The following is a description of a gene set: Mouse Gene Set: GOBP_ORGANIC_HYDROXY_COMPOUND_TRANSPORT studied in species Mus musculus The directed movement of an organic hydroxy compound (organic alcohol) into, out of or within a cell, or between cells, by means of some agent such as a transporter or pore. An organic hydroxy compound is an organic compound having at least one hydroxy group attached to a carbon atom., and this is the list of marker genes: Slco1c1, Gnat1, Gramd1c, Asic3, Kcne2, Apoa5, Slc2a13, Star, Ces1f, Xlr4a, Slc51b, Slc10a6, Slc5a11, Htr6, Nfkbia, Abcd3, Sec24a (NCBI Gene Id 77371), Kcnk9, Spp1, Cyp7a1, Syk, Prkn, Shh, Trem2, Stard3nl, Tor1a, Abca8a, Dtnbp1, Nfkb1, Abca5, Slc22a3, Fev, Htr7, Relch, Abca2, Slc18a3, Aqp9, Grm2, Kcnq1, Gpihbp1, Gpm6b, Hrh3, Vps4b, Agtr2, Abca12, Zdhhc8, Fcer1g, Apof, Itgb3, Nos1, Park7, Tspo, Emb, Nisch, Vapa, Drd3, Slc22a1, Lrp1, Bmp6, Ralbp1, Htr1b, Ldlrap1, Tmem97, Nr1h4, Abca7, Nr1h2, Mexis, Abca13, Abca1, Vip, Slc29a3, Aqp8, Slc18b1, Chrna4, Cd300a, Ces1d, Apoa4, Sncg, Atp8b1, Kdm5b, Rab3a, Agt, Oxt, Cav1, Ttc39d, Slc22a2, Ces1a, Slc6a4, Adipoq, Mip, Gdnf, Tgm2, Grk2, Slc16a1, Vps53 (VPS53 GARP complex subunit), Ghrl, Scp2, Abcb4, Rtn4, Tspo2, Nucb2, Actb, Drd2, Maob, Drd1, Flvcr1, Apoc2l, Npc1, Abcg1, Pltp, Arl8b, Pink1, P2ry12, Slco1a1, Gramd1b, Kpna4, Cftr, Ecrg4, Fcer1a, Mfn2, Nmb, Comt, Myo5a, Osbp, Pcp4, Furin, Adora3, Adora2a, Aqp7, Lamtor1, Xlr4b, Sirt1, Hnf1a, Tpcn2 (NCBI Gene Id 233979), Abcc2, Npc1l1, Smpd3, Slc5a12, Abcb11, Slc10a4-ps, Abca3, Rab3b, Nat8l, Oxtr, Snca, Stx12, Slc10a5, Ptch1, Flvcr2, Apoa1, Pip4k2a, Nus1, Myb, Slc10a4, Aqp2, Lipg, Slc16a8, Abcg8, Lipc, Ces1h, Vps52, Apoc2, Ces1c, Slc18a2, Abcc3, Prkcb, Slc44a1, Entpd1, Gps2, Lrp6, Slc10a3, Crhr2, Rbp4, Chga, Crhr1, Vps51, Slco1a6, Soat2, Oprk1 (opioid receptor, kappa 1), C1qtnf1, Cadps, Vapb, Stard5, Ptgs1, Ffar3, Abcg5, Apom, Slc5a8, Abat, Slc10a7, Plcd1, Slc6a2, Ceacam1, Adora2b (NCBI Gene Id 632506), Xbp1, Stra6l, Cartpt, Vps54, Npc2, Egf, Pla2g10, Apoc3, Nrg1 (NCBI Gene Id 320603), Ptpn11, Naxe, Tsku, Slc6a3, Chrnb2, Slc10a1, Slc26a6, Lcat, Myc (myelocytomatosis oncogene), Apob, Agtr1a, Crh, Slco1a4, Ptger3, Cnr1, Washc1, Slc16a3, Ceacam2, Snord60 (small nucleolar RNA, C/D box 60), Slc51a, Fgf15, Osbpl2, Soat1 (sterol O-acyltransferase 1), Stra6, Chrna6 (NCBI Gene Id 58169), Aqp11, Chrna7, Acacb, Slco1a5, Slc16a7 (NCBI Gene Id 71535), Syt11, Htr2a, Nr0b2, Sdhd, Mttp, Ly6e, Nr1h3, Ghsr, Eepd1, Stx1a, Slco1a7, Anxa2, P2rx1, P2ry1, Pcsk9, Scarb1, Cxcl12, Arv1, Slc29a4, Slco1b2, Gramd1a, Dab2, Ces1b (NCBI Gene Id 382044), Cyp19a1, Igfbp3, Commd1, Gal, Ldlr (NCBI Gene Id 16835), Yjefn3, Aqp3, Lipa, Slc5a3, Npy2r, Ren1, Mapk15, Chrm5, Pparg, Slc18a1, Aqp1, Tmf1, Osbpl6, Vps4a, Fcgr3, Tac1, Syt7, Galr1, Slc49a4, Kcnb1, Abcg4, Ces1e, Gck, Spg11, Mecp2, Cd36, Serac1, Stard3, Slc44a2, Syt1, Selenom, Slco2b1, Srebf2, Slco1a8, Slc10a2, Wnk4, Htr1a, Pon1, Slc19a2, Apoc1, Apoa2, Gabbr1, Irak1, Apoe, Ces1g, Syt4, Ttc39b, Abca8b, Pomc, Msr1 (NCBI Gene Id 20288), Lgals3, Kcna2, Abcc4 (NCBI Gene Id 239273), Slc19a3, Stard4